The following is a description of a gene set: The chemical reactions and pathways involving a cyclic nucleotide, a nucleotide in which the phosphate group is in diester linkage to two positions on the sugar residue. Human Gene Set: GOBP_CYCLIC_NUCLEOTIDE_METABOLIC_PROCESS species: Homo sapiens, and this is the list of marker genes: ADCY8, PDE7A, PDE4A, PDE8A, NPR2, PDE10A, GUCY1B1, GUCY2C, ADCY5, PTHLH, ADCY4, PDE8B, ADCY7, PDE4C, NPPC, PDE1A, ADCY1, GUCY2D, NPR1, NPPA, PDE4D, AMPD2, GUCY2F (guanylate cyclase 2F, retinal), PDE5A, NPPB, EPHA2, ADCY10, PDE9A, ADCY2, PTH, ADCY9, CACNB4, PDE7B, RORA, GUCY1A1, ADCY6, PDE2A, PDE4B, GUCY1A2, ADCY3, CNP